The following is a description of a gene set: studied in species Homo sapiens Human Gene Set: OCT1_01 Genes having at least one occurrence of the motif NNNNWTATGCAAATNTNNN in the regions spanning 4 kb centered on their transcription starting sites. This matches the POU2F1 transcription factor binding site V$OCT1_01 (v7.4 TRANSFAC)., and this is the list of marker genes: THAP2, SKIL, EGR2, ATP1B2, OTX2, WNT6, TTI2, LPL, TSPYL2, SLC7A11, ID4, CADM1 (NCBI Gene Id 337934), BARHL2, GNB3, MCC, C1orf122, SYNPR, HNF1B, H3C3, MAF, NEUROG1, ZSCAN20, TP53INP2, TAS1R2, ZNF428, E2F3, ATF7IP, FCHSD1, H2BC21, HOXD11, LETM2, CITED2, SCML4, BEND4, SFRP2, PRDM10 (PR/SET domain 10), PRKG1, H2AC21, HOXA5, SPIB, MBIP, MMP1, RHOB, FTHL17, SPTY2D1, PHOX2B, RAB26, HOXC5, KLHL1, CLCA3P, H2AC14, PFKFB1, CD180, H3-3B, ATP6V0C, HORMAD2, SRSF8 (serine and arginine rich splicing factor 8), SEL1L3, REL, PTEN, EPHB3, SPRR2A, MYF5, ALDH1A1, FZD4, SLC24A3, KCTD4, CPD, NDP, BRINP3, ADNP, ZNF423, NR2F2, ANK3, CES5A, CDC42EP3, CXXC4, SRF, LLGL2, BTK, NUDT3, PBX1, SLC24A1, IGSF21, RHOBTB2, TCF4, ZFY, TRPS1, LRRN1, ZBTB32, UPK3A, CSRNP3, PCDH8, LIPG, LINC00470, TRAF3IP2, PDE4D, LHX6, DLL3, IRX2-DT, CRACR2B, VGLL3, LYN, GAB2, DMD, H2AC6, FGF20, PLPPR2 (NCBI Gene Id 64748), PPP1CC, ZEB2 (zinc finger E-box binding homeobox 2), UBE2S, HOXB6, OPA3, CSMD3, ID3, NRL, LMO4, GPR42, GPR85, MTUS1, NRXN3, TBXAS1, PROKR2, GCM1 (NCBI Gene Id 8521), IL25, NR6A1, PRR34, PDGFRB, NFIA, HPCAL4, DOK3, GPC4, FOXP1, ACTG2, NEDD4, NFYB, CPA4, CADM2, STAG1, SIAH3, SH3BGRL, SLC25A35 (solute carrier family 25 member 35), UTP18, H2BC14, SGCA, PCDH20, DLX1 (distal-less homeobox 1), TSNAX, TMSB4XP8, ASXL1, SLC19A3, CDR2L, PPP2R3A, RCAN1, SEC22A, H2AC20, MID1, YRDC, DIP2B, KIF13A, SLITRK6, KLF12, CCND1, PLEKHA6, NSMCE3, CCN1, H2AC25, LMO3, MITF, TCF12, ZHX2, NRXN1, NEIL3, LCOR, C10orf71, TMSB4XP4, CACNA1C, MIR17HG, H2BC3, PYGO1, NUFIP2, FOXN1, NFIX, PDZRN4, PAX6, POU2F1, ZBTB20, ASCL3, DLGAP4, EGLN3 (NCBI Gene Id 63900), SPATA31H1, DYNLT5, TSC1, DNAH7, CRYZL1, ATOH1, COLCA1, NDUFA4L2, CDX2, GRHL3, ALK, PIM2, ITSN1, POU3F4, C2CD5, JARID2, SESN3, SREBF2, KRT222, BCOR, MPPED2, SKIDA1, DGKG, KCNJ13, HIVEP3, RHOBTB1 (Rho related BTB domain containing 1), ZFC3H1, ING1, TMSB4XP1, PMEL, NIN, HDAC9 (NCBI Gene Id 9734), SNCAIP, ITPR3, DUSP6, CSNK1A1L, CSN1S1, PRRC2A, ETV1, BCO2, NKX2-2, SLC25A12 (NCBI Gene Id 8604), HOXA3, TBR1, SYT1, CEP41, SLC1A2, IRAK1, H2BC4, FAM117A, EMILIN3, ZFX (zinc finger protein X-linked), THRA, KCNN3, UQCC2 (ubiquinol-cytochrome c reductase complex assembly factor 2), HOXA10, FBXO24, PCDH1, NEK10, SLC6A15, SERTAD4, GPR4, PHC2, SP6, NXT2, CDK2 (NCBI Gene Id 1017), SOX5, ACBD4, NXPH1, GUCA1A, CSF3, MAP2K6, LRCH4 (leucine rich repeats and calponin homology domain containing 4), DNAH5, TMSB4XP6, ITPRIP, COL25A1, TSPAN13, ADORA2A, FEZF2, IRX2